The following is a description of a gene set: species: Mus musculus Mouse Gene Set: GOBP_POSITIVE_REGULATION_OF_BIOMINERAL_TISSUE_DEVELOPMENT Any process that activates or increases the frequency, rate or extent of biomineral tissue development, the formation of hard tissues that consist mainly of inorganic compounds., and this is the list of marker genes: Isg15, Wnt6, Alox5, Cd276, Bmp4, Ltf, Ano6, Osr1, Acvr2b (activin receptor IIB), Bmp7, Odaph, Tfap2a, Pkdcc, Bmpr1a, Mia3, Dspp, Ccn1, Kl, Wnt10b, Acvr2a, Acvr1, Atp2b1, Ptn (NCBI Gene Id 19242), Cftr, Amtn, Nell1, Atf4, Slc20a2 (solute carrier family 20, member 2), Fzd9, Enam, Asxl2 (ASXL transcriptional regulator 2), Tmem119, Slc8a1 (solute carrier family 8 (sodium/calcium exchanger), member 1, NCBI Gene Id 319418), Bmp6, Csf1r, Fam20c, Adgrv1, Smad3, Fbxo5, Gpm6b, Wnt4, Atraid, Pth, Rxra, Bmp2, Vdr, Adrb2, Mef2c, Slc4a2 (solute carrier family 4 (anion exchanger), member 2), Bmpr1b, Actn3, Osr2, Cebpb, P2rx7, Bmpr2, Fgfr3, Rxrb (NCBI Gene Id 20182), Fbn2 (NCBI Gene Id 407822), Tent5a